The following is a description of a gene set: Any process that modulates the frequency, rate or extent of attachment of spindle microtubules to kinetochore involved in mitotic sister chromatid segregation. species: Homo sapiens Human Gene Set: GOBP_REGULATION_OF_ATTACHMENT_OF_MITOTIC_SPINDLE_MICROTUBULES_TO_KINETOCHORE, and this is the list of marker genes: KAT2B, KAT5, BIRC5, SIRT1, CDK1 (NCBI Gene Id 983), BECN1, AURKB, CDCA8, INCENP, HNRNPU